The following is a description of a gene set: studied in species Mus musculus from publication Chen Y, Wang X (PMID 31504780) Mouse Gene Set: MIR_188_3P Genes predicted to be targets of miRBase v22 microRNA mmu_miR_188_3p in miRDB v6.0 with MirTarget v4 prediction scores > 80 (high confidence targets)., and this is the list of marker genes: Nexmif, Snrk, Plekhf2, Ddah1, Dcaf11, Wnk1, Senp2, Rgs7bp, Zfp592, Fut10, Zfp974, Senp7, Pag1, Pianp, Fry, Dok4, Ugt2b5, Gm4841, Surf4, Gtf3c6, Grpr, Fbxo42, Zfp780b, Set, Ino80d, Ippk, Zfp811, Trim24, Gmeb2, Nr6a1, Zfp318, Fah, Kdm8, Gpx4, Ganab, Smap2, Zhx2, Tdpoz1, Myot, Tlr1, Zfp367, R3hcc1l, Tshz3, Zmynd11, Zfp607b, Dnmt3a, Zfp59, Usp27x, Tmed9, Pdxdc1, Ptpn12, Corin, Dnajc3, Psd3, Elovl4, Tusc2, Zfp641, Ell2 (NCBI Gene Id 192657), Tdpoz9, Ptbp2, Zfp626, Lrrc57, Syt7, Prr15, Cd209e, Nrn1, Larp1, Slc7a11, Ube3c, Sertad1, Nceh1, Tomm22, Csnk2a1, Ptprt, Zfp616, Rab22a, Aak1, Med1, Nalf1, Rusf1, Tmtc3, Klrk1, Zfp874b, Nfatc3, Ddi2, Arpp21, Zfp619, Mnat1, 5730480H06Rik, Ano9, Spta1 (NCBI Gene Id 98361), Fzd5, Mettl8 (methyltransferase 8, methylcytidine), Cap1, Ube2d3, Elp4, Neurog2, Zfp704, Zfp735, Negr1, Ldb2, Krtap21-1, Rnaseh2b, Yars1, Zfp850, Gcc1, Tardbp, Atxn1, Stra6l